Given this list of marker genes SLC1A6, SLC1A2, STXBP1, SLC1A1, SNAP25, RAB3A, SYT1, PPFIA3, GLS2, ARL6IP5, SLC17A7, RIMS1, GLS, STX1A, VAMP2, UNC13B, SLC38A2, PPFIA2, SLC1A3, PPFIA1, CPLX1, TSPOAP1, PPFIA4, SLC1A7, here is a description of the gene set: Reactome Pathway: Glutamate Neurotransmitter Release Cycle Communication at the synapse involves the release of glutamate from the presynaptic neuron and its binding to glutamate receptors on the postsynaptic cell to generate a series of events that lead to propagation of the synaptic transmission. This process begins with the formation of synaptic vesicles in the presynaptic neuron, proceeds to the loading of glutamate into the vesicles, and concludes with the release of glutamate into the synaptic cleft.<br><br>The glutamate life cycle in the neuron begins with the loading of the nascent synaptic vesicles with cytosolic glutamate with the help the transporter protein, VGLUT1, located in the synaptic vesicular membrane. Glutamate loaded vesicles are formed in the cytoplasm and then transported to a site close to the plasma membrane where the vesicle is docked with the help of several proteins. One of the key players in the docking process in Munc 18, which interacts with syntaxin (in the plasma membrane), MINT (Munc18 interacting molecule), and DOC2. These interactions along with the secondary interactions are needed for docking the synaptic vesicle to the plasma membrane.<br><br><br>The docked synaptic vesicle is not ready for release until it undergoes molecular changes to prime it for fusion with the plasma membrane. Munc13 is one of the main players in the priming process. Munc 13 interacts with RIM (Rab3A interacting molecule) located in the synaptic vesicle. Munc 13 also interacts with DOC2. The precise molecular mechanisms of the interactions that result in docking versus priming are not clear and the docking and priming process have been combined in this annotation of this pathway. Once primed the synaptic vesicle is ready for release.<br><br><br>Synaptic transmission involves an action potential that is generated in the presynaptic cell which induces the opening of voltage gated Ca2+ channels (VGCC) located in the plasma membrane of the presynaptic neuron. Typically N, P/Q and R type of VGCCs are involved in the neurotransmitter release. Ca2+ influx through these channels results in the rise of intracellular Ca2+ concentration. In the microdomain of glutamatergic synapses, the Ca2+ concentration could rise between 10-25 micro molar. Synaptotagmin, a Ca2+-binding protein located in the synaptic vesicular membrane, responds to the rise in the Ca2+ levels in the microdomain and induces a synaptic vesicle membrane curvature that favors vesicle fusion. Fusion of the synaptic vesicle with the plasma membrane is characterized by the formation of a trimeric trans-SNARE complex that involves VAMP2 from the synaptic vesicle membrane, and syntaxin and SNAP-25 from plasma membrane. Vesicle fusion incorporates the synaptic vesicle membrane into the plasma membrane, releasing the vesicle contents (glutamate) into the synaptic cleft. Postfusion the synaptic vesicle membrane proteins (VAMP2, Rab3A, VGLUT1, and synaptotagmin) are also found in the plasma membrane. part of: Neurotransmitter release cycle species: Homo sapiens